The following is a description of a gene set: from publication Chessler AD, Unnikrishnan M, Bei AK, Daily JP, Burleigh BA (PMID 19201883) species: Homo sapiens Genes down-regulated in skin after injection of Trypanosoma cruzi (strain Y): wildtype (BALB/c) versus INFG knockout. To investigate the early host response triggered by three different strains of Trypanosoma cruzi at a local infection site, changes in host gene expression were monitored in a murine intradermal infection model using Affymetrix oligonucleotide arrays. Robust induction of IFN-stimulated genes (ISGs) was observed in excised skin 24 hours post-infection where the level of ISG induction was parasite strain-dependent with the least virulent strain triggering a muted IFN response. Infection of mice immunodepleted of IFNγ-producing cells or infection of IFNγ-deficient mice had minimal impact on the IFN response generated in T. cruzi infected mice. In contrast, infection of mice lacking the type I IFN receptor demonstrated that type I IFNs are largely responsible for the IFN response generated at the site of infection. These data highlight type I IFNs as important components of the innate immune response to T. cruzi the site of inoculation and their role in shaping the early transcriptional response to this pathogen. We used microarrays to detail the local host transcriptional response to intradermal T. cruzi infection in WT mice and mice depleted of NK cells, or deficient in IFN-gamma or type I IFN responses. Additionally we compared the local host-transcriptional response generated to infection with 3 different strains of Trypanosoma cruzi (Y, Brazil, and G). Human Gene Set: GSE13522_WT_VS_IFNG_KO_SKING_T_CRUZI_Y_STRAIN_INF_DN, and this is the list of marker genes: RNF167, SSTR5, ANO6, ENTPD6, ADARB2, TNFRSF1A, PSME1, BRD8, CCR8, TKTL1, RASGRP2, TBXA2R, VAV1, ALS2CL, SEC24C, CC2D1B, ADCY2, SCARNA13, AQP7, OXSM, OCIAD2, HHIPL2, LELP1, LYPLA1, ACBD7, GLYAT, HDX, PLCXD2, DDX51, ZAR1L, EML1, MAP6D1, CDC42BPA, GFI1, XPNPEP3, TMX4, NUCKS1, SYCN, CACNB3, SLC12A7, CRLF3, GLYCTK, NDRG3, MBTPS1, DDX23, CYB5B, GPR12, GALNT12, CDYL2, FAM83F, ASB2, INTU, GGCX, GSN, LIMS1, MN1, TAF9B, CNIH3, ACSS2, SERPINB12, SMURF2, TMEM156, SEPTIN2, ECSCR, NRF1 (NCBI Gene Id 4899), GDPD2, SRPRA, ZFP14, HNF1A, PRKD3, ENTPD5, HMGB1, LALBA, SYT17, VPS33B, FAM83B, ACER1, DENND2B, CSNK2A2, ZNF512B, CYB5D2, LDHAL6B, SGTB, SORCS1 (sortilin related VPS10 domain containing receptor 1), ORAI2, ATP6V1A (ATPase H+ transporting V1 subunit A), ASPM, TSSK4, SRP19, GOSR1, RALYL, ARHGAP25, CD5, REPS2, CRY2, LGALS2, MMP3, CTDP1, NCF1, PEX2, TWNK, IL6, EHMT1, FGF17, SHROOM4, CBX7, BBOX1, HMG20A, KIF14, SIRT1, GRPEL2, DCAF1, CAMTA1, FCER1A, MIR542 (NCBI Gene Id 664617), OPTC, TMEM170B, MYL2, HIF1AN, KDM4B, MIA2, TMC6, FAM3A, ANK2, LENG1, ATF3, CD300LG